The following is a description of a gene set: species: Mus musculus Mouse Gene Set: REACTOME_SENSORY_PERCEPTION_OF_TASTE Sensory perception of taste, and this is the list of marker genes: Tas2r106, Scnn1a, Tas2r130, Tas1r1, Scnn1g, Itpr3, Gnb3, Tas2r119, Tas2r144, Tas2r138, Tas2r120, Tas2r136, Tas2r108, Tas2r137, Tas2r126, Tas2r140, Gnat3, Gnb1, Tas2r121, Tas1r3, Tas1r2, Tas2r139, Tas2r118, Scnn1b, Gng13